Given this list of marker genes Ccdc88a, Ghr, Svil, Slco1a6, Aak1, Arid1b, Arl5a, Srsf10, Mthfsl, Gm17455, Meioc (meiosis specific with coiled-coil domain), Ippk, Nln, Zcchc3, Rbms3, Dennd4c, Zcchc9, Stx7, Nap1l5, Tsg101, Dnajc13, Zhx3, Fgl2, Zfand6, Rbm7, Trim33, Sox1, Wrn, Golph3l, Ppp1r36, Skic3, Calr, Pcmtd2, Slc4a4, Fbxl4, Rnf115 (ring finger protein 115), Rps6ka3, Sp8, Chrnb3, Vti1a, Crh, Mgat4a, Nufip2, Nktr, Ireb2, Gnb5, Zmym4 (NCBI Gene Id 67785), Tmc1, Mcm3ap, Serp1, Cyp39a1, Hipk3, Angptl1, Glrx, Klhl38, Icam1, Slco1a1, Mapk6, Mthfs, Lrrfip2, Slc35f1, Ipo11, Fgf1, Cstad, Rps25, Grpr, Nfix (nuclear factor I/X), Rasgrp1, Bmf, Scel, Tox3, Nfyb, Cyp2j11, Yy1, Cpsf2, Nr5a2, here is a description of the gene set: Genes predicted to be targets of miRBase v22 microRNA mmu_miR_5625_3p in miRDB v6.0 with MirTarget v4 prediction scores > 80 (high confidence targets). Mouse Gene Set: MIR_5625_3P species: Mus musculus from publication Chen Y, Wang X (PMID 31504780)